Given this list of marker genes LGI4, FGFBP3, MIA, ENSG00000231252, CRABP1, SOX10, NGFR-AS1, KCNJ10, COL20A1, LRRTM1, SYNPR, TTYH1, MYOT, ALDH1A1, NRXN1, NGFR, TMEM176A, TMEM176B, CCDC160, SYT10, COL28A1, FXYD1, SLC35F1, AZGP1, OLFML2A, HEY2, GRIK3, CLDN14, LRRN1 (leucine rich repeat neuronal 1), STK32A-AS1, INSC, PTPRZ1, LINC03048, MMD2, SOX2, SEMA3G, MYO16-AS1, PLEKHB1 (NCBI Gene Id 58473), TRPM3, SV2B, LAMP5, EXTL1, OPRK1, GINS3, GJC3, STAC2, CNTN2, ARHGEF26-AS1, CNMD (chondromodulin), SLITRK6, NKAIN4, MEGF10, LINC01339, UGT8, H1-9P, DHH, GFRA1, WNT16, PRDM16, CDH6, DLX1, LYPD1, S100B, PTX3, WFDC2, XKR4, PPP2R2B, LPL, PRDM16-DT, PPP1R1C, TMEM132B, BCAN, HSPB2, SHC4, HEY1, ALOX15, TCP11, GPR17, GPR83, SHISA9, DTX4, TSPAN11, GRIN2B, CRISPLD1, CSMD1, MATN4 (NCBI Gene Id 8785), TAC1, C2orf72, GPC1, LINC01505, ATP10B, ATP1A2, LGI2, LINC01748, MIR9-2HG, MYOZ1, RXRG (retinoid X receptor gamma), SOX8, PMP2, CDH19, COL18A1, CHL1, SLITRK2, AGRN, ERBB3, ADAMTS8, ZNF804B, PRIMA1, KCNA2, MPZ (NCBI Gene Id 4359), CNP, FOXD3, TRDN, FOXD3-AS1, PMEPA1, ADAM23, MCAM, METRN, GAL3ST1, LINC00327, LINC00511, CHST9, PLP1, SCRG1, LINC00645, SCN7A, GPM6B, ART3, HEPACAM, LINC00466, here is a description of the gene set: Human Gene Set: DESCARTES_FETAL_ADRENAL_SCHWANN_CELLS Marker genes curated from the annotated cluster as represented in the Descartes Human Gene Expression During Development database. The gene expression program underlying the specification of human cell types is of fundamental interest. The study authors generated human cell atlases of gene expression and chromatin accessibility in fetal tissues. For gene expression, the study authors applied three-level combinatorial indexing to >110 samples representing 15 organs, ultimately profiling ~4 million single cells. The study authors leveraged the literature and other atlases to identify and annotate hundreds of cell types and subtypes, both within and across tissues. Our analyses focused on organ-specific specializations of broadly distributed cell types (such as blood, endothelial, and epithelial), sites of fetal erythropoiesis (which notably included the adrenal gland), and integration with mouse developmental atlases (such as conserved specification of blood cells). These data represent a rich resource for the exploration of in vivo human gene expression in diverse tissues and cell types. studied in species Homo sapiens from publication Cao J, O'Day DR, Pliner HA, Kingsley PD, Deng M, Daza RM, Zager MA, Aldinger KA, Blecher-Gonen R, Zhang F, Spielmann M, Palis J, Doherty D, Steemers FJ, Glass IA, Trapnell C, Shendure J (PMID 33184181)